The following is a description of a gene set: Human Gene Set: PANGAS_TUMOR_SUPPRESSION_BY_SMAD1_AND_SMAD5_DN Genes down-regulated in ovarian tumors from mouse models for the BMP SMAD signaling (gonad specific double knockout of SMAD1 and SMAD5). species: Mus musculus from publication Pangas SA, Li X, Umans L, Zwijsen A, Huylebroeck D, Gutierrez C, Wang D, Martin JF, Jamin SP, Behringer RR, Robertson EJ, Matzuk MM (PMID 17967875) The transforming growth factor beta (TGFbeta) family has critical roles in the regulation of fertility. In addition, the pathogenesis of some human cancers is attributed to misregulation of TGFbeta function and SMAD2 or SMAD4 mutations. There are limited mouse models for the BMP signaling SMADs (BR-SMADs) 1, 5, and 8 because of embryonic lethality and suspected genetic redundancy. Using tissue-specific ablation in mice, we deleted the BR-SMADs from somatic cells of ovaries and testes. Single conditional knockouts for Smad1 or Smad5 or mice homozygous null for Smad8 are viable and fertile. Female double Smad1 Smad5 and triple Smad1 Smad5 Smad8 conditional knockout mice become infertile and develop metastatic granulosa cell tumors. Male double Smad1 Smad5 conditional knockout mice are fertile but demonstrate metastatic testicular tumor development. Microarray analysis indicated significant alterations in expression of genes related to the TGFbeta pathway, as well as genes involved in infertility and extracellular matrix production. These data strongly implicate the BR-SMADs as part of a critical developmental pathway in ovaries and testis that, when disrupted, leads to malignant transformation., and this is the list of marker genes: HIF1A, INPPL1, YBX1, MINDY3, TOX, IGF2R, GREB1L (GREB1 like retinoic acid receptor coactivator, NCBI Gene Id 80000), PTBP3, LYRM9, GSTK1, NIPA2, ICAM4, SERPINA3, MFSD2A, INSYN2B, KNSTRN, GREB1, UGCG, TNFSF11, CNTROB, SUSD4, BORA, TMEM185B, EXT1, MUS81, PLEKHD1, BMPR1B, GABRA1, SRSF7 (serine and arginine rich splicing factor 7), CNOT6, CLN8, EFCAB11, MEG3, TANGO2, LHCGR, IGFBP2, ARL5B, ADCK5, ATP1A1, MAPK9, CERT1, HSD17B1, CHST8, DNAJA4, UTP14A, SLFN12, USP3, TMEM268, OSGIN2, LDLR, RAB33A (RAB33A, member RAS oncogene family), FOSL2, SLC16A1, ID1, PARL, YIPF4, TULP2, ACSL3, QSOX1, CNTF, C11orf24, INHBB, MEG8, SUPT16H, SREBF2 (NCBI Gene Id 6721), BRAF, ANAPC7, ARRDC4, ZSWIM7, MRPS21, SRBD1, ERGIC2, CBS, LRP8, FGFRL1, DRD4, MAP3K7, NFKB2, SUCO, SCD, LRP11, WFS1, DUSP9, ABCA7, NPPC, SRPRB, HM13, RIMKLB, HMGB2, RBBP4, HSPA13, COMP, MFAP3L, KSR1, RSRP1, LRIG2, TOM1L1, CORO7, HCN1, ARL6IP1, ELOVL6, RACK1, PAIP1, NPR2, FAM234A, MAPRE2, GABRB2, MASP1, PCDH18, MFAP3 (NCBI Gene Id 4238), RGS13, PPT2 (NCBI Gene Id 9374), LARGE2, WAPL, SDF2L1, GREM1, CHFR, ASTN1, ALMS1, PIGO, PLEKHH1, TMX1, FDFT1, OLFM1, ZDHHC2, RCE1, LPCAT1, FAM161A, ALG12, ELOVL2, PRLR, TMED1, MAGEA13P, LBR, DAB1, TMEM39A, LIFR, TMEM30A, HAUS7, GPX7, SPTY2D1, TXK, GPD2, RBMX, CYRIB, DNAJC10, MAPKBP1, MAX